Given this list of marker genes CDK2, H2AX, DLGAP5, EZH2, CDCA8, DCLRE1A, RTKN2, MCM7, MCM3, KIF20A, CMC2, EXO1, BRCA1, GINS2, TTK, HAUS3, DTL, UBE2T, USP1, MAD2L1, QSER1, FBXO5, SMC2, PAICS, DEK, CDT1, CCNA2, WDHD1 (WD repeat and HMG-box DNA binding protein 1, NCBI Gene Id 11169), CEP55, MTFR2, RPA2, POC1A, DCTPP1 (NCBI Gene Id 79077), E2F8, DTYMK, RFC4, NEK2, MCM2, LBR, CHAF1B, NCAPH2, KIFC1, TOPBP1, TRIP13, RFC5, GINS3, HMGB3, NUSAP1, DSN1, MAGOHB, HAUS8, CENPA, TIMELESS, MYBL2, SAP30, KIF22, HMGB2, CDCA5, KNTC1, TPRKB, PIMREG, PARPBP, MCM5 (minichromosome maintenance complex component 5), CENPK, NUP88, GMNN, SULF2, LMNB1, UHRF1 (ubiquitin like with PHD and ring finger domains 1), DNAJC9, RANBP1, E2F1, MCM6, KIF11 (kinesin family member 11), RACGAP1, GPN3, SEMA3B, RAD54L, SOD3 (superoxide dismutase 3), PCLAF, GASK1B, RAD51, F10, FABP5, here is a description of the gene set: from publication Zhou T, Chou J, Mullen TE, Elkon R, Zhou Y, Simpson DA, Bushel PR, Paules RS, Lobenhofer EK, Hurban P, Kaufmann WK (PMID 17404513) Human Gene Set: ZHOU_CELL_CYCLE_GENES_IN_IR_RESPONSE_6HR Cell cycle genes significantly (p =< 0.05) changed in fibroblast cells at 6 h after exposure to ionizing radiation. studied in species Homo sapiens The changes in global gene expression in response to DNA damage may derive from either direct induction or repression by transcriptional regulation or indirectly by synchronization of cells to specific cell cycle phases, such as G1 or G2. We developed a model that successfully estimated the expression levels of >400 cell cycle-regulated genes in normal human fibroblasts based on the proportions of cells in each phase of the cell cycle. By isolating effects on the gene expression associated with the cell cycle phase redistribution after genotoxin treatment, the direct transcriptional target genes were distinguished from genes for which expression changed secondary to cell synchronization. Application of this model to ionizing radiation (IR)-treated normal human fibroblasts identified 150 of 406 cycle-regulated genes as putative direct transcriptional targets of IR-induced DNA damage. Changes in expression of these genes after IR treatment derived from both direct transcriptional regulation and cell cycle synchronization.